Given this list of marker genes SLC22A4, DPYSL3, NID2, HMOX1, FGFR1, GNG11, DDR2, TRAM2, ANPEP, DDAH1, MACROH2A1, CYBRD1, PRMT2, PTX3, MARCKS, CDK5RAP2, SDC2, AP1S2, ALDH6A1, TAF9B, RIMS1, NREP (NCBI Gene Id 9315), MAP1B, LTBP2, NID1, WNT5B, CITED2, ARL3, PLAAT3, PCOLCE, COL1A2, PLOD2, BLMH, MAGED2, GLRX, RHOBTB3, MAGED1, ZBTB16, PPP1R3C, WIPF1, FLOT1, DLC1, NUPR1, NR2F1, PIP4K2A, TRPA1, SCG5, TRBC2, WNT5A, RHOBTB1, EPHB2, SERPINE1, ACKR1, COL5A1, GALNT10, GULP1, CREB3L1 (NCBI Gene Id 90993), MITF, CRIP2, ARID5B, BGN, NLRP1, AAMDC, IGFBP3, PRR3, HOXA5, ITGA7, FBN1, DNAJB4, PDGFRL, DOCK4, KLF4, TBL1X, SYT11 (NCBI Gene Id 92303), SLC7A2, PID1, PRKCA, FBLN1 (NCBI Gene Id 2192), TRAK2, NPTX2, NRP1 (NCBI Gene Id 8829), TPM1, UGDH, FLVCR2, ZCCHC24, DAB2, PRAF2, LTBP1, RGS17, ITGBL1, ADAM12, PRRX1, CDH11, CCDC92, DUSP1, BPGM, RNASE4, ENOX1, KCNMA1, NEBL, SNED1, CYFIP2, BIN1, LEPR, FBLN5, NECTIN3, NAV2, FAM50A, ANXA6, TFPI, C14orf132, PODXL, FAT4, MIOS, ENSG00000291006, LPAR1, SLITRK5, LRIG1, DOCK10, COL6A1, GADD45B, RCAN2, AOX1, ENO2, ARHGEF40, UQCRB (ubiquinol-cytochrome c reductase binding protein), CYTIP, CADM3, MOXD1 (monooxygenase DBH like 1), PMP22, HAS2, BICC1, MMP19, SV2A, EML1, TNFAIP6, LOX, ARHGAP22, IGFBP7, KLF9, TOX, ARMCX2, ABCA8, FZD2, ACKR3, SPOCK1, REPIN1, CDKN2C (cyclin dependent kinase inhibitor 2C), VCAN, SEPTIN11, EPS8, PLPP3, ROR1 (receptor tyrosine kinase like orphan receptor 1), KCNJ6, ZEB1, FN1, SEMA5A, COL6A3, IGFBP4, MYBL1, COL1A1, ASMTL, PTGER4, REPS2, CILK1, PPM1H, PRR16, ANOS1, CCNE2, ATP6V0E2, CDH2, ENPP1, FOXN3, RGL1, GYPC, THY1, KDELR3, TAGLN, CYP1B1, MFAP2, PCDH9, ZNF22, ITGA10, SDC3, JAM3, PXDC1 (PX domain containing 1), RGS4, MICAL2, CHST2, GREM1, ABLIM3, PCOLCE2, POSTN, DCN, ACTA2, SRR, FKBP5, RECK, GLRB, AGTR1, NNMT, CCN2, MMP2, GRB10, CLEC3B, COL6A2, MLLT3, GK, CHN1 (chimerin 1), SYNE1, OLFML3, SYNM, MME, MAGEH1, COL5A2, MLPH, SLC46A3, SRGN (NCBI Gene Id 5552, serglycin), TSC22D3, SERPINF1, PPARG, CDH18, LIN7A, GSTA4, ZFHX4, BBOF1, FTL, MYL9, SPARC, COL3A1, STARD13, KAT2B, RNFT2, SIX2, PRUNE2, MARCHF3, SATB2, LMCD1, PTGFR, COL8A1, DGKI, STC2, RPS6KA2, PTGER2, FERMT2, BEX4, IL17RC, WIPI1, TWIST1, SHROOM2, NAP1L3, KANK2, ENPP2, TCEA2, PNMA2, SEPTIN6, TGFBR3, here is a description of the gene set: studied in species Homo sapiens Human Gene Set: ONDER_CDH1_TARGETS_2_UP Loss of the epithelial adhesion molecule E-cadherin is thought to enable metastasis by disrupting intercellular contacts-an early step in metastatic dissemination. To further investigate the molecular basis of this notion, we use two methods to inhibit E-cadherin function that distinguish between E-cadherin's cell-cell adhesion and intracellular signaling functions. Whereas the disruption of cell-cell contacts alone does not enable metastasis, the loss of E-cadherin protein does, through induction of an epithelial-to-mesenchymal transition, invasiveness, and anoikis resistance. We find the E-cadherin binding partner beta-catenin to be necessary, but not sufficient, for induction of these phenotypes. In addition, gene expression analysis shows that E-cadherin loss results in the induction of multiple transcription factors, at least one of which, Twist, is necessary for E-cadherin loss-induced metastasis. These findings indicate that E-cadherin loss in tumors contributes to metastatic dissemination by inducing wide-ranging transcriptional and functional changes. from publication Onder TT, Gupta PB, Mani SA, Yang J, Lander ES, Weinberg RA (PMID 18483246) Genes up-regulated in HMLE cells (immortalized nontransformed mammary epithelium) after E-cadhedrin (CDH1) knockdown by RNAi.